Given this list of marker genes RMRP (NCBI Gene Id 6023), KMT2D, HACE1, KDM6A, PCNA, here is a description of the gene set: species: Homo sapiens Absent pubertal growth spurt Human Gene Set: HP_ABSENT_PUBERTAL_GROWTH_SPURT The abrupt and transient increase in the annual growth rate normally observed in adolescent individuals does not occur.